Given this list of marker genes CREB1, GOLGA7, IFT80, A1CF, PIN1, WFS1, SOX4, LAMP1, PIM1, WIZ, AFM, HIP1, TSPAN1, LAMP2, TAF1, DSC3, TRIM39, PDRG1, TREX1, SPPL2C, GRN, UFL1, GNAQ, DVL1, ASDURF, MIR101-1, WDR81, STXBP4, PPP1CA (NCBI Gene Id 5499), DNAAF10, PPIB, IFT46, TBRG1, NAA15, NCLN, PAQR4, CDC37L1, STK4, COA8, TBL1X, STXBP1 (NCBI Gene Id 6812), CRTAP, CRYAB, DVL3, RABL3, IFI30, CDC37, AAK1, STK3, MSX1, CALR, USP7, DNAJA3, ZNF207, RUVBL1, SAXO1, PARK7, HSP90AA2P, FREY1, CRYAA, ZBED3, PARVA, RPL5, WNT10B, NPM1, C10orf90, TP53, BAG1, PHB2, TESC, MDM4, BAG5, USP27X, NAA30, RUVBL2, PTGES3, CLU, PYURF, HSP90AB2P, USP19, TRIM37, USP13, TYROBP, HPS4, HOXB-AS3, CAMLG, GAPDH (glyceraldehyde-3-phosphate dehydrogenase), CBLC, CSN3, BAG2, EFNA1, MARCHF7, CCT6A, SEL1L (NCBI Gene Id 6400), PHB1, NLK, AHSP, SMO, MORC3, PDCL3, SOX17, TMC6, ZSWIM7, PRKRA, PEX6, SMAD3, PPP1R10, GET1, GTPBP4, ABTB3, TAF9, PLPP3, SAV1, GPIHBP1, TSC1, FLOT2, USP2, MAPK8IP3, CHEK2, SEC16A, APOA1, TMEM88, TTI2, HCFC1, APOA2, SUMO1, DSG1, PRKCD, VHL, HSPA1B (heat shock protein family A (Hsp70) member 1B), MYCNOS, RPL11, CEP63, TNIP2, PIH1D2, MT3, MCM8, DNAAF2, HIP1R, PFDN6, RPAP3, DNLZ, CSNK2A1, NOP53, STX12, TELO2, PIK3R1, PER3, MTMR9, CPN2, BAG3, OTUD3, COG7, PFDN2, PFN2, GLMP, RAB21, PML, USP9X, RPL23, HSP90AB3P, ATP1B2, UXT, TRIM44, CCNH, MUL1, HSPA1A, ANK2, PIH1D1, HYPK, RPS7, TAF9B, RASSF2, HSPD1, MTOR, CCT2, SPAG1, STUB1, PRKN, H1-5, USP36 (ubiquitin specific peptidase 36), GBA3, HAPSTR2, SMAD7, CCT5, BBOF1, PFN1, MFSD1, UBR4, ATP1B1, NCKAP1, ATP1B3, AKT2, CCT8, KDF1, USP33, FLOT1, PDCD10, EPHA4, HSP90AB1, IP6K2, CDKN2A, TCP1, MFSD8, COG3, SYVN1, DCAF11, RTN4 (NCBI Gene Id 57142), PINK1, SWSAP1, CDK7, FBXW7, HSP90AB4P, CCT4, PTEN, FLNA, IGF1, CCT3, TTI1, TMC8, UBE2B, PPARGC1A, BRINP1, PEX19, CREBL2, P3H1, NAA16, PYHIN1, CD74 (NCBI Gene Id 972), CTNND1, PIM2, HSP90AA1, RASSF1, NAPG, BAG6, POLR2E, BAG4, USP29, URI1, CCT7, CHP1, EP300, IRGM, here is a description of the gene set: species: Homo sapiens Any process involved in maintaining the structure and integrity of a protein and preventing it from degradation or aggregation. Human Gene Set: GOBP_PROTEIN_STABILIZATION